Given this list of marker genes NAGA, CDK1, POU6F1, DGCR6, POLA1, CDC37, RNF130, MBOAT1, CDK5RAP2, SLC37A1, SPIDR, MAPK9, PLEC, BAZ2B, XIST, CNTLN, NUP93, SSBP1, PLCB2, SMARCD2, PLXDC2, SH3GL1, CPT1A, MYC, EEPD1, EXOC4, IRAG2, CORO1C, ANKRD24, GNAI1 (NCBI Gene Id 2770), IRF1, CREB3L2, MTBP, AAAS, ARHGEF1 (NCBI Gene Id 9138), RCC2, COTL1, PRMT2, RPL19, HEXB, TFEB, NUDT13, ADAM19, RFC2 (replication factor C subunit 2), PDXK, HR, CLK4, PEX3, SLC66A1, RPS15A, DOCK5, CINP, ALDH18A1, TUBB2A, CHRND, RPS3, CIC, CYP4A11, UPK3A, WIPF1 (WAS/WASL interacting protein family member 1), FGR, MCM7 (minichromosome maintenance complex component 7), DPH7, PLEKHA2, ITGA6, ECHDC1, MTFR2, CCDC6, KLHL7, TNFRSF9, KLHDC4, MTOR, SCARB2, ATG5, CALHM2, MRPL39, RAB7A, ANKRD13A, TLCD4, NSDHL, AQR, DOP1B, TOR3A, POLR3GL, TEX261, PLCL2, IGSF6, NDRG4, KDM3A, STK38, PIP5K1C, COMT, SYNJ2BP, TTC5 (tetratricopeptide repeat domain 5), FUCA1 (NCBI Gene Id 2517), ITPR3, RREB1, NPR1, KCNK2, ABCG1, FAM50A, RAB5IF (NCBI Gene Id 55969), PXMP4, LACTB, RIOK3, RPL14, DHX16, SUN2 (NCBI Gene Id 25777), MAGEB4, CORO1A, CRIP1, PRIM2, SH2D1B, TRAPPC10, TNFRSF12A, LASP1, RAB9A, PLXNB2, NBEAL2, WDR45, HMGB2, RPA3, SCMH1, IRF9, MTIF2, HMGA1, SGK1, MUTYH, FMNL1, RETREG1, HFE, ATP11B, INTS6, SCIN, PLEKHF2, PHKA2, S100A8, IL15RA, KCNAB2, ASPH, ABHD15, FUNDC1, TMEM37, PLXDC1, ITPK1, RUFY3, GINS1, FAM149B1, ACIN1, SLCO5A1, PHIP, PTPA, TMEM14C, HIBADH, PNRC1, BNIP3L, KLC1, LMAN2, EVL (Enah/Vasp-like), NIT1, RPL28, COQ5 (coenzyme Q5, methyltransferase), STOM, UBXN1, EN2 (engrailed homeobox 2), PCK2, MYO7A, ZBTB14, THAP12, RPS21, BET1, WAS, KCNN4 (NCBI Gene Id 3783), TOB1, CLDN23, PTPRR, CLPS, SNAPIN, PDCD2, SNTB2, HTATIP2, NUP88, TNNI3, ALDOA, CASP9, ANGPTL2, CRYBB2, PSMG1, GRN, CIB1, TPST2, KDM2B, MEF2C, ASCC2, COQ9, GTPBP1, IQGAP2, LAMP1 (lysosomal associated membrane protein 1), HACD4, here is a description of the gene set: from publication Amit I, Garber M, Chevrier N, Leite AP, Donner Y, Eisenhaure T, Guttman M, Grenier JK, Li W, Zuk O, Schubert LA, Birditt B, Shay T, Goren A, Zhang X, Smith Z, Deering R, McDonald RC, Cabili M, Bernstein BE, Rinn JL, Meissner A, Root DE, Hacohen N, Regev A (PMID 19729616) mouse primary BMDCs were stimulated with tlr ligands and gene expression changes were profiled on Affymetrix arrays Human Gene Set: GSE17721_LPS_VS_POLYIC_6H_BMDC_DN Genes down-regulated in comparison of dendritic cells (DC) stimulated with LPS (TLR4 agonist) at 6 h versus DC cells stimulated with poly(I:C) (TLR3 agonist) at 6 h. studied in species Homo sapiens